The following is a description of a gene set: Genes positively differentially expressed in cell type: CD4+ T cell upon treatment with cytokine: IFN-γ in mouse lymph nodes in vivo. Cytokines mediate cell-cell communication in the immune system and represent important therapeutic targets. A myriad of studies have highlighted their central role in immune function, yet we lack a global view of the cellular responses of each immune cell type to each cytokine. To address this gap, the authors created the Immune Dictionary, a compendium of single-cell transcriptomic profiles of more than 17 immune cell types in response to each of 86 cytokines (>1,400 cytokine-cell type combinations) in mouse lymph nodes in vivo. A cytokine-centric view of the dictionary revealed that most cytokines induce highly cell-type-specific responses. For example, the inflammatory cytokine interleukin-1β induces distinct gene programmes in almost every cell type. A cell-type-centric view of the dictionary identified more than 66 cytokine-driven cellular polarization states across immune cell types, including previously uncharacterized states such as an interleukin-18-induced polyfunctional natural killer cell state. Mouse Gene Set: CUI_T_CELL_CD4_IFNG_RESPONSE_UP studied in species Mus musculus from publication Cui A, Huang T, Li S, Ma A, Pérez JL, Sander C, Keskin DB, Wu CJ, Fraenkel E, Hacohen N (PMID 38057668), and this is the list of marker genes: Ppa1, Plaat3, Epsti1, Bst2, Socs1, Sp110, Psme2, Treml2, B2m, Zup1, Itgb7, Selenow, Ifi203, Samhd1, H2-Q4, Dtx3l, H2-D1 (histocompatibility 2, D region locus 1), Trafd1, Mndal, Ifit1, Ms4a4c, Slfn1, Isg20, Wars1, Tapbpl, Gbp3, Parp11, Itm2b, Ifit3, Iigp1, Oasl2, Ifi206, Gbp8, Tap1, Gbp5, Psmb10, Igtp, Dbnl, Stat2, Ctss (cathepsin S), Tpm3, Gbp9, Ms4a4b, Samd9l (sterile alpha motif domain containing 9-like), Phgdh, Tgtp2, Ifi208, Slfn5, Gbp4, Etnk1, H2-T22, Isg15, Psmb9, Nmi, Usp18, Phf11c, Psma2, Apobec3, Slfn8, Zbp1, Gbp7, Ms4a6b, Parp14, Irf2, Pml, Gimap4, Lpp, Tmsb10, Ifi213, Daxx, Ly6a, Ly6c1, Oas3, Rnf114, Nlrc5, Ifi35, Psma4, Psmb8, Art2b, Ly6e, Irf7, Tap2, Irf9, Rnf213, Mthfd2, Rigi, Sec61g, Psme1, Pdia3, Irf1, Irgm2, Ifit1bl1 (interferon induced protein with tetratricpeptide repeats 1B like 1), Trim30a, Pdk1, Psma7, Cd274, Gbp6, Trim12c, Tapbp, Irgm1, Parp10 (NCBI Gene Id 671535), Stat1, H2-DMa, Phf11b, Trim12a, Stat3, Ifi27l2a, Irf8, Calhm6, Ssbp2, H2-T23, Gbp2, Xaf1, H2-K1, Idnk, Ifi47, Tgtp1 (T cell specific GTPase 1), Parp9, Insl6, Nampt, St6galnac4 (ST6 (alpha-N-acetyl-neuraminyl-2,3-beta-galactosyl-1,3)-N-acetylgalactosaminide alpha-2,6-sialyltransferase 4), Rtp4, Sp140